The following is a description of a gene set: species: Mus musculus The inactivation of gene expression that occurs after transcription. Mouse Gene Set: GOBP_POST_TRANSCRIPTIONAL_GENE_SILENCING, and this is the list of marker genes: Mir33, Tarbp2, Fxr1, Mael, Mir200b, Mirlet7c-2, Hnf1a, Helz2, Piwil2, Cnot8, Piwil1, Mir155, Mir3960, Tial1, Fmr1, Mir7578, Mir101a, Mir21a, Mir200a, Mir450b, Mir451a, Mir1a-2, Mir7-2, Mir135a-1, Mir1247, Ncbp1, Mir205, Focad, Ago1, Mirlet7c-1, Mir182, Mir489, Mir873a, Mir423, Dhx9, Mir100, Cnot1, Endou, Mir505, Ncbp3, Eloc, Lin28a, Mir26a-1, Mir495, Mir34a, Celf1, Mir21b, Mov10l1, Lin28b, Mir196b, Gigyf2, Mir504 (NCBI Gene Id 100124476), Elob, Bmp4, Mirlet7a-1, Clp1, Mir124a-2 (NCBI Gene Id 723950), Mir129-1, Mir125b-1, Carlr, Dgcr8, Mirlet7a-2, Eif6, Piwil4, Pum1, Mir133a-1, Mir154, Mir125a, Mir351, Mir301, Tnrc6a, Mir125b-2 (NCBI Gene Id 723952), Tnrc6b, Tsnax, Mir124a-1, Mir124-2hg, Mir133a-2, Mir146, Eif4g1 (eukaryotic translation initiation factor 4, gamma 1), Mir9-1 (microRNA 9-1), Zc3h10, Ajuba, Mirlet7e, Mir221, Mir96 (NCBI Gene Id 723886), Mir186 (NCBI Gene Id 387181), Mir124a-1hg, Stat3, Mir361, Mir107, Dicer1, Mir511, Wtip, Mir10a, Ripk1, Zmpste24 (zinc metallopeptidase, STE24), Pum2, Mir26a-2, Mov10, Mir143, Rbm4, Xpo5, Mir183, Mir324, Trp53, Mirlet7g (microRNA let7g), Mir451b, Helz, Mir21c, Ddx6, Mir196a-2, Adar, Dnd1, Cnot7, Eif4e2, Trub1, Ago2, Mir17, Celf2, Mir874, Mir101b, Bcdin3d, Mir875, Tgfb1, Eif4enif1, Trim71, Zswim8, Ncbp2, Gtsf1, Zfp36, Mecp2, Mir30a, Ago4, Mir196a-1, Mir26b, Tnrc6c, Mir137, Mir214, Mir129-2, Mir223, Mirlet7b, Mir34c, Limd1, Mir7-1, Mir124a-3 (NCBI Gene Id 723951), Elavl1, Il6, Mir1a-1, Cnot6, Ago3, Mir494, Mir203, Mir23a, Tent2, Mir668, Tsn